Given this list of marker genes JAK2, BRI3, TCERG1L, YBX1, KDM3A, ELAVL2, GATAD2B, CHSY3, RANBP10, SSX2IP, ZFC3H1, TMEM161B, MAPRE1, CAPZA2, ARID1A, MSL3, MICAL2, PTPRT (protein tyrosine phosphatase receptor type T), KLF13, DAZAP1, HNRNPM, ADGRL3, RAB10, RAB6C, ADIPOR1, PARP12, SMG1, FBXO33, ZBTB4, NACC1, ZNF653, WDFY3, VANGL2, CUX2, PPP1R9B (protein phosphatase 1 regulatory subunit 9B), NAA15, LAMC1 (NCBI Gene Id 3915), POM121, MYBBP1A, RPGRIP1L, EGR3, OLIG3 (NCBI Gene Id 167826), SMC4, NHLH2 (nescient helix-loop-helix 2), CEMIP, GPBP1L1, KRT80, MBNL2, PRKCE, AP3S1, NCOA1, GABRA1, ZFP91, AKT1S1, SORBS2, PCCA, GPR85, ETF1, ESYT3, MATR3, VCPIP1, TNPO2, NETO1, CSK, GPBP1, RAB6A, RAB11A, BUB3, TNFRSF11B, ANKRD16, TBX3, TMEM106B, DCLK1, ZBTB2, CRYZL1, CADM1, NHS, SLC24A3, CRIM1, OSBPL11, SP4, BCL11B, HSBP1, MMP16, YTHDF3, DRD1, BCL9, IKZF4, ITCH, COL12A1, RP2, UBN1, MEF2D, PTEN, RNF138, ADAMTS6, CCDC28A, HTR2C, CEP192, EML4, PPM1B, PDIK1L, KRAS, LINC03042, SRR, CPEB4, SMAD7, here is a description of the gene set: Genes having at least one occurence of the motif TGAGATT in their 3' untranslated region. The motif represents putative target (that is, seed match) of human mature miRNA hsa-miR-216 (v7.1 miRBase). species: Homo sapiens Human Gene Set: TGAGATT_MIR216